Given this list of marker genes Cyth4 (NCBI Gene Id 72318), Tubb1 (NCBI Gene Id 72817), Tubb4a, Mical1, Sra1, Tubb2b, Ehd2, Parp3, Cdc6, Qsox1, Klhl22, Ska1, Arl13b, Gstm4, Tubb5, Cdca8, Kcnv1, Tubb3, Hsd3b2, Kif20b, Pcnt, Cdc7, Hsd3b6, Krr1, Hsd3b9, Gstm6, Rpgrip1, Aamp, Trim45, Phldb1, Fan1, Prc1, Cenpe, Hsd3b5, Prkci, Fkbp6, Dctn1, Tpx2, Hsd3b8, Rab35, Tubb6, Nek2, Fam50b, Cep131, Setx, Eaf1, Mical3, Rbm18, Gpx2, Tmem9, Agbl5, Tubb4b, Cep55, Kics2, Rab11fip3, Haus3, Pik3r4, Rfxank (NCBI Gene Id 19727), Kmt5b, Xpa, Dnajc8, Gstm1, Nisch, Pycr3, Phlpp2, Tubb2a, Ift43, Dusp11, Fam83d, Nudcd2, Usb1, Epb41, Nupr1, Ncaph2, Apc2, Septin9, Hsd3b3, Iqcb1, Unc119, Septin2, Pcif1, Anapc7, Klhdc8b, Dnali1, Gstm7, Kif23, Rbm44, Esrra, Kif20a, Chrna2, Tex14, Wapl, Pknox2, Ngrn, Cd34, Gstm2, Adrb2, Gstm3, Flnc, Rmdn3, Snrnp25, Dzip1l, Olfm4, Hsd3b4, Klk6, Acot12, Hsd3b1 (NCBI Gene Id 51882), Mtus2, Kif2b, Hnf4g, Opn1sw, Jpt1, Arhgap33os, Gstm5 (NCBI Gene Id 14866), Ppp1r13l, here is a description of the gene set: studied in species Mus musculus Mouse Gene Set: GOCC_INTERCELLULAR_BRIDGE A direct connection between the cytoplasm of two cells that is formed following the completion of cleavage furrow ingression during cell division. They are usually present only briefly prior to completion of cytokinesis. However, in some cases, such as the bridges between germ cells during their development, they become stabilised.